Given this list of marker genes ABCA3 (ATP binding cassette subfamily A member 3), HYDIN, IFT56, FNIP1, PAK2, SFTPC, AGR2, here is a description of the gene set: Radiological appearance of increased density around the walls of a bronchus or large bronchiole. This feature is thought to be related to edema involving the bronchial wall as well as the peribronchial interstitial space. If the cross section of a bronchus is captured in a radiograph or computed tomography image, it is said to have the appearance of a donut because of the central lucency representing the airway of the bronchus surrounded by a circular region of increased density. Bronchial wall thickening Human Gene Set: HP_BRONCHIAL_WALL_THICKENING studied in species Homo sapiens